The following is a description of a gene set: species: Mus musculus A structure found in the nucleolus, which contains nearly completed preribosomal particles destined for the cytoplasm. Mouse Gene Set: GOCC_GRANULAR_COMPONENT, and this is the list of marker genes: Rrp1b, Surf6, Clec3b, Ctcf, Cdkn2a, Carf, Fbl, Npm1, Cdkn2aip